The following is a description of a gene set: Genes with intermediate-CpG-density promoters (ICP) bearing histone H3 trimethylation mark at K4 (H3K4me3) in ES cells (embryonic stem). Mouse Gene Set: MEISSNER_ES_ICP_WITH_H3K4ME3 DNA methylation is essential for normal development and has been implicated in many pathologies including cancer. Our knowledge about the genome-wide distribution of DNA methylation, how it changes during cellular differentiation and how it relates to histone methylation and other chromatin modifications in mammals remains limited. Here we report the generation and analysis of genome-scale DNA methylation profiles at nucleotide resolution in mammalian cells. Using high-throughput reduced representation bisulphite sequencing and single-molecule-based sequencing, we generated DNA methylation maps covering most CpG islands, and a representative sampling of conserved non-coding elements, transposons and other genomic features, for mouse embryonic stem cells, embryonic-stem-cell-derived and primary neural cells, and eight other primary tissues. Several key findings emerge from the data. First, DNA methylation patterns are better correlated with histone methylation patterns than with the underlying genome sequence context. Second, methylation of CpGs are dynamic epigenetic marks that undergo extensive changes during cellular differentiation, particularly in regulatory regions outside of core promoters. Third, analysis of embryonic-stem-cell-derived and primary cells reveals that 'weak' CpG islands associated with a specific set of developmentally regulated genes undergo aberrant hypermethylation during extended proliferation in vitro, in a pattern reminiscent of that reported in some primary tumours. More generally, the results establish reduced representation bisulphite sequencing as a powerful technology for epigenetic profiling of cell populations relevant to developmental biology, cancer and regenerative medicine. from publication Meissner A, Mikkelsen TS, Gu H, Wernig M, Hanna J, Sivachenko A, Zhang X, Bernstein BE, Nusbaum C, Jaffe DB, Gnirke A, Jaenisch R, Lander ES (PMID 18600261) species: Mus musculus, and this is the list of marker genes: Atp6v1g2, Rnf208, 2810408A11Rik, Fv1, Zfp599, Lsg1, Capn1, Tbc1d22b, Mpi, Palm3, Rbm4, Stoml1, Wdr83os, Zik1, Prpf31, 4833420G17Rik, S1pr4, Gdap1l1, Rpl19 (ribosomal protein L19), Rab13, Kcnip2, Nckap5, Ccdc160, Triqk, Ppp2r3c, Shank2, Rttn, Pak6, Fam3a, Tlr2, Eppk1, Col6a2, Drc3, Nosip, Tal2